Given this list of marker genes SLC25A2, AZIN2, HNF4A, ARG1, ALDH18A1, ARG2, OTC, ASL, here is a description of the gene set: The chemical reactions and pathways involving ornithine, an amino acid only rarely found in proteins, but which is important in living organisms as an intermediate in the reactions of the urea cycle and in arginine biosynthesis. studied in species Homo sapiens Human Gene Set: GOBP_ORNITHINE_METABOLIC_PROCESS